The following is a description of a gene set: Genes involved in glycolysis; based on literature and sequence annotation resources and converted to Affymetrix HG-U133A probe sets. from publication Mootha VK, Lindgren CM, Eriksson KF, Subramanian A, Sihag S, Lehar J, Puigserver P, Carlsson E, Ridderstråle M, Laurila E, Houstis N, Daly MJ, Patterson N, Mesirov JP, Golub TR, Tamayo P, Spiegelman B, Lander ES, Hirschhorn JN, Altshuler D, Groop LC (PMID 12808457) Human Gene Set: MOOTHA_GLYCOLYSIS species: Homo sapiens DNA microarrays can be used to identify gene expression changes characteristic of human disease. This is challenging, however, when relevant differences are subtle at the level of individual genes. We introduce an analytical strategy, Gene Set Enrichment Analysis, designed to detect modest but coordinate changes in the expression of groups of functionally related genes. Using this approach, we identify a set of genes involved in oxidative phosphorylation whose expression is coordinately decreased in human diabetic muscle. Expression of these genes is high at sites of insulin-mediated glucose disposal, activated by PGC-1alpha and correlated with total-body aerobic capacity. Our results associate this gene set with clinically important variation in human metabolism and illustrate the value of pathway relationships in the analysis of genomic profiling experiments., and this is the list of marker genes: PFKFB2 (NCBI Gene Id 5208), BID, CD4, GPI, HK1, ALDOC, ENO2, PFKM, TPI1, PFKFB1, PGAM2, GAPDHS, ENO3, PGM1, FBP1, ENO1, ALDOB, PKM, PGK1, ALDOA, FBP2